Given this list of marker genes EEF1A1, PRKCB, CDH1, ACTR2, SPTA1, MYH9, MISP (NCBI Gene Id 126353), GYS2, NUMA1, VCL, TRPV4, FCHSD1, KNCN, GSN, SPTBN2, SPTAN1, SELE, SPTBN5, SPTB, COBL, EPB41L2, TRPC4, TMOD1, PCLO, WASL, HIP1, CIB2, LASP1, AKAP13, MTSS2, CAPZB, CAPZA3, SNX9, TPM4, DLG4, IQGAP1, CTTN, DLC1, MYADM, MAEA, GMFB, CLASP2, KRT19, DMTN, CALB1, RAPGEF3, CORO1A (coronin 1A), FLOT2, PDE4DIP, CFL1, ANLN, CALD1 (NCBI Gene Id 800), CAPZA2, SHROOM4, SPTBN4, SHROOM2, LLGL2 (NCBI Gene Id 3993), SHROOM1, CLDN5, LANCL2, MYRIP, CALB2, BSN, MAPRE1, RTKN, SLC2A1, PIEZO1, HIP1R, NF2, DBN1, FLOT1, CDH2, ACTB, PJVK, MYZAP, NSMF, EPB42, RDX, WDR1, ACTN3, PIEZO2, SPTBN1, CAP1, NOS2, SHROOM3, LLGL1, EZR, CAPN2, ACTN4, SLC4A1, MED28 (mediator complex subunit 28), CLASP1, ACTN2, COTL1, MLPH, GYPC, EPB41, MYO1A, ACTN1, GMFG, CAPZA1, TMC2, FLNA, PLEKHH2, PLS1, PPP1R9A, MPP1, DSTN, PPP1R9B, here is a description of the gene set: species: Homo sapiens The portion of the cytoskeleton that lies just beneath the plasma membrane. Human Gene Set: GOCC_CORTICAL_CYTOSKELETON